Given this list of marker genes METTL14, IGDCC4, CNNM4, PPP1R17, FGB, PLBD1, RASA3, UACA, SYT17, SCRN3, PCGF5, WTAP, MAP3K1, NSD3, ZFHX4, CA10, PSMB6 (proteasome 20S subunit beta 6), EOLA1, MECP2, VAPB, PRR27, GAD2, FBN1, HS2ST1, GLCE, INTS2, GDF11, SH3KBP1, KLF7 (NCBI Gene Id 8609), GAB1, NUDT4, TUBGCP3, CDK17, CAPS2, ZNF618, PBX2, ANP32E, YME1L1, CYP8B1, PARP12 (poly(ADP-ribose) polymerase family member 12), BTAF1, PGK1 (NCBI Gene Id 5230), CSGALNACT2, EXOC6, GPBP1, RPS6KB1, LSM14A, ALDH1A2, TRIM37, SMCHD1, ZFAND6, SLF2, CSNK1A1, LBH, ITGB1BP1, MRTFB, DYNC2I1, NIPAL1, BMX, SPTLC3, FUT9, RIMS2, PLEKHA1, GM2A, SEC11A, ONECUT2, EEF1A1, C1orf21 (chromosome 1 open reading frame 21), TRAPPC1, GBP5, JUN, BRD3, MMAB (NCBI Gene Id 89909), APPL1, NRG1, TKTL2, ZNF592, TAF11, SP8, HIF1A, TBC1D9, CACNG4, WWC3, MEIS1, RBM15B, COL25A1, ERCC6, PAQR9, CPEB3, ZFHX3, OSMR, DNM3, TBCC, SOWAHC, TNPO1, ZNF761, TWF1, COPG2, ZFP36L1, C6orf47 (chromosome 6 open reading frame 47), PNPLA8 (patatin like phospholipase domain containing 8), ARHGEF26, CLU, TBL1XR1, C5orf63, RIT1, CNTF, HACD4, MAP3K9, RAB33B, ARPC1A, HLF, PWWP2B, VPS41, AMMECR1, FEM1C, USP13, SNTG1, RNF217, ATP6V0B, ALKBH4, KATNAL1, KLHL13, MAP4K4, SDC2, SEC24B, HRH4, KBTBD8, SBSN, CSNK1A1L, PALLD, FNDC3B, NCK1, GPR153, SLC33A1, BCLAF1, SRSF1, ITPR1, PLET1, HIPK3, ZNF701, AREG, ERI1, PPP2CA, ZFR, RTRAF, ACSL1, GON7, NCSTN, NR2F2, JOSD1, THAP9, SLC6A6, RTN4, RBM7, SCN1A, MIER1, here is a description of the gene set: studied in species Homo sapiens from publication Chen Y, Wang X (PMID 31504780) Human Gene Set: MIR4504 Genes predicted to be targets of miRBase v22 microRNA hsa-miR-4504 in miRDB v6.0 with MirTarget v4 prediction scores > 80 (high confidence targets).